Given this list of marker genes GPR101, HPGD, CDH23, PRKAR1A, SLCO2A1, KCNJ11, PMM2, GNAS, IGF1, CDKN2C, CDKN1A, CDKN1B, AIP, CDKN2B, MEN1, PDE11A, here is a description of the gene set: Acromegaly is a condition resulting from overproduction of growth hormone by the pituitary gland in persons with closed epiphyses, and consists chiefly in the enlargement of the distal parts of the body. The circumference of the skull increases, the nose becomes broad, the tongue becomes enlarged, the facial features become coarsened, the mandible grows excessively, and the teeth become separated. The fingers and toes grow chiefly in thickness. Human Gene Set: HP_ELEVATED_CIRCULATING_GROWTH_HORMONE_CONCENTRATION species: Homo sapiens Elevated circulating growth hormone concentration